Given this list of marker genes GGCX, NOS1, NF1, SNCA, PRKN, GPM6B, SYT11, ASIC1, SLC30A1, PNKD, here is a description of the gene set: species: Homo sapiens Any process that stops, prevents, or reduces the frequency, rate or extent of the directed movement of a neurotransmitter into, out of or within a cell, or between cells, by means of some agent such as a transporter or pore. Human Gene Set: GOBP_NEGATIVE_REGULATION_OF_NEUROTRANSMITTER_TRANSPORT